Given this list of marker genes ABCA13, FASLG, GPS2, ACSL5, ATP8A2, ABCG4, PLA2G4A, PPARG, CAV1, TREM2, DENND5B, COMMD1, CETP, SIRT1, NR1H3, PTGES, ACSL1, TMEM30A, DBI, PRELID1, PLA2G3, SCP2, DAB2, CYP4A11, MIR206, PLTP, ECRG4, APOE, APOA1, PRKCD, ABCG1, EDN1, PRAP1, GAL, BMP6, IL1B, OXT, RXRA, MIF, RETN, ZDHHC8, TAC1, TMF1, ERFE, PLA2R1, ADIPOQ, LIPG, C1QTNF1, PON1, P2RX4, ANXA2P2, GALR1, LRAT, ABCA1, CES1, SPP1, ATP8A1, TNFSF11, TRIAP1, NFKB1, LPCAT3, NR1H2, ABCA8, EEPD1, NMB, P2RX7, CYP19A1, ABCA3, GHRL, NKX3-1, CYP4F2, NTSR1, MYB, ABCA12, ANXA2, ABCB4, LRP1, PLA2G10, AVPR1B, FABP3, PTCH1, LDLRAP1, TNFRSF11A, ABCA7, CRH, XRCC4, ABCA5, here is a description of the gene set: Human Gene Set: GOBP_POSITIVE_REGULATION_OF_LIPID_TRANSPORT Any process that activates or increases the frequency, rate or extent of the directed movement of lipids into, out of or within a cell, or between cells, by means of some agent such as a transporter or pore. studied in species Homo sapiens